The following is a description of a gene set: species: Mus musculus Mouse Gene Set: TABULA_MURIS_SENIS_BLADDER_LEUKOCYTE_AGEING from publication Tabula Muris Consortium (PMID 32669714), and this is the list of marker genes: Fabp5, Ccl5, Gm5547, Lgals3, Lag3, Rnf149, B2m (beta-2 microglobulin), H2-K1, Sprr1a, Rbp4, Dkk2, Ccl8, AW112010, Cd63, Chchd2